Given this list of marker genes Hmgcs1, Lss, Sc5d, Fasn, Cyp51, Me1, Acss2, Pcsk9 (NCBI Gene Id 230573), Idi1, Fdps, Hsd17b7, Fdft1, Insig1 (insulin induced gene 1), Rdh11, Aacs, Acly, Pmvk, Acaca, Elovl6, Sqle, Stard4, Tm7sf2, Ldlr, Aldoc, here is a description of the gene set: studied in species Mus musculus from publication Horton JD, Shah NA, Warrington JA, Anderson NN, Park SW, Brown MS, Goldstein JL (PMID 14512514) The synthesis of fatty acids and cholesterol, the building blocks of membranes, is regulated by three membrane-bound transcription factors: sterol regulatory element-binding proteins (SREBP)-1a, -1c, and -2. Their function in liver has been characterized in transgenic mice that overexpress each SREBP isoform and in mice that lack all three nuclear SREBPs as a result of gene knockout of SREBP cleavage-activating protein (SCAP), a protein required for nuclear localization of SREBPs. Here, we use oligonucleotide arrays hybridized with RNA from livers of three lines of mice (transgenic for SREBP-1a, transgenic for SREBP-2, and knockout for SCAP) to identify genes that are likely to be direct targets of SREBPs in liver. A total of genes showed statistically significant increased expression in livers of transgenic SREBP-1a mice, 505 increased in livers of transgenic SREBP-2 mice, and 343 showed decreased expression in Scap-/- livers. A subset of genes met the stringent combinatorial criteria of induction in both SREBP transgenics and decreased expression in SCAP-deficient mice. Of these genes, 13 were previously identified as direct targets of SREBP action. Of the remaining genes, 13 encode enzymes or carrier proteins involved in cholesterol metabolism, 3 participate in fatty acid metabolism, and 4 have no known connection to lipid metabolism. Through application of stringent combinatorial criteria, the transgenic/knockout approach allows identification of genes whose activities are likely to be controlled directly by one family of transcription factors, in this case the SREBPs. Mouse Gene Set: HORTON_SREBF_TARGETS Genes up-regulated in liver from mice transgenic for SREBF1 or SREBF2 and down-regulated in mice lacking SCAP.